Given this list of marker genes TSR1, FIRRM, IARS1, NUP98, PRPS1, MNS1, RFC3, PUS1, EIF2B3, NME1 (NME/NM23 nucleoside diphosphate kinase 1), CDK1, MCM6, RGS4 (NCBI Gene Id 5999), RBM28 (NCBI Gene Id 55131), ELK1, CDC6, MAZ, PARPBP, RRM2 (ribonucleotide reductase regulatory subunit M2), DLEU2, ID1, SNRPD3, TOE1, MCFD2, SEH1L (SEH1 like nucleoporin), COA7, FASN, EBNA1BP2, PKMYT1, RAD51AP1, ODC1, PARP2, TSEN2, CHAF1A, POLR2L, SAR1B, MCM2, POLR1G (RNA polymerase I subunit G), UTP20, TELO2, DNAJC9, SEC23IP, WDR4, PPIF, GINS2, HEATR3, RB1, H2AX (NCBI Gene Id 3014), DHCR24, MTERF3, MLLT10, FXN, IPO4, MPHOSPH9, HNRNPU, RPP40, GNPDA1, TOP3A, FERMT1, PRMT5, LMNB2, DKC1, FUS, TUBG1, CCNE2, VRK1, PUM3, ATP13A3, CUTC, NUP160, RUVBL1, NCS1, VWA8, CENPS, UTP14A, EXOSC8, TIPIN, IDE, SHCBP1, RRP9, MRPL40, HMGA1, VARS1, DHFR, SNRPA1, MRPS12, MAD2L1, MCM10, SLC25A15, MCM3, KIF23, RSAD1 (NCBI Gene Id 55316), ERCC6L, PAIP1, POLE2, SRSF2, TFAM, TTLL4, TPX2, URB2, SKP2, GLRX2, RPP30, BOP1, FBXO5, UBIAD1, PCYT2, NOP16, GEMIN2, ZNG1A, PBK, NLE1, PDSS1, GART, HNRNPDL, NASP, SCLY, POLD2, DDX18 (NCBI Gene Id 8886), RRP1B, ENPP1, BYSL, C3orf52, DBF4, DHCR7, GEMIN6, AASDHPPT, STIL, GCSH, EIF2S1 (eukaryotic translation initiation factor 2 subunit alpha), GINS1, CPN2, GPD1L, ADISSP, METTL2B, ABCF2, PPAT, NOL11, RANBP1, NUP85, FAM136A, HEATR1, CISD1, COQ2, UMPS, POP7, ORC6, TUBB4B, RXYLT1, EXO1, FANCG, NVL, NAT10, SLC25A10, BUD23, NUP205, FANCI, AKAP1, SH2D1A, HACD3, UCHL5, PRC1, MRTO4, SLC5A6, NEK4, PDCD2, NCAPD3, NOLC1, BRCA1, PSMC3IP, FEN1, ATIC, CTPS1, RRM1, EEF1E1, PWP2, PSMG1, WDR12, POLR3G, DDX23, USP39, ZWILCH, SLCO4A1, PAK1IP1, WDR77, MTNAP1, MTHFD1, HNRNPD (heterogeneous nuclear ribonucleoprotein D), PNO1, NUP43, OIP5, ASF1B, LRP8, SNAPC5, ARMC6, CLPB, MFN2, NUP188, ACAT2, H3C4, TSFM (Ts translation elongation factor, mitochondrial), POLR3K, LETM1, RRS1, DDX21, PCLAF, SNRPD1, HMBS, IDH3A, POMT2, ZWINT, NIF3L1, PA2G4, EXOSC2, GRWD1, GTPBP4, NOL12, PHB1, SLC11A2, MRPL46, NUSAP1 (NCBI Gene Id 82534), RFC2, RPL39L, NDUFAF4, MCM5, YARS1, NARS2 (asparaginyl-tRNA synthetase 2, mitochondrial), WDR74, PSME3, PFAS, CCNE1, MAP2K3, RAD51, PRMT7, MELK, DDX19A, TRIP13, AIMP2, DHX35, CAD, GATB, RITA1, GK, PSME4, CENPN, AMDHD2, SRM, CSE1L, LBHD1, GINS3, USP1, POP5, C1QBP, BOLA2, SRRT, PPARD, DNA2, DDX11, PSMD11, MCM4, CCNA2, EMG1, RRP15, SACS, PARP1, RFC5, TRAF3IP3, SLC1A5 (NCBI Gene Id 6510), BARD1 (NCBI Gene Id 580), FBXO42, DGCR11, SLC19A1, TOR3A, CEP83, CDC7, BCS1L, HJURP, ELOVL6, RRP1, URB1, ILF3, GMNN, DLAT, CIAO1, POLA2 (DNA polymerase alpha 2, accessory subunit), CCNF, UBE2S, SPDL1, TUBGCP4, NOP56, NCLN, here is a description of the gene set: species: Homo sapiens Hypoxia-inducible factor 1 (HIF-1) activates transcription of genes encoding angiogenic growth factors, which are secreted by hypoxic cells and stimulate endothelial cells, leading to angiogenesis. To determine whether HIF-1 also mediates cell-autonomous responses to hypoxia, we have compared gene expression profiles in arterial endothelial cells cultured under nonhypoxic versus hypoxic conditions and in nonhypoxic cells infected with adenovirus encoding beta-galactosidase versus a constitutively active form of HIF-1alpha (AdCA5). There were 245 gene probes that showed at least 1.5-fold increase in expression in response to hypoxia and in response to AdCA5; 325 gene probes showed at least 1.5-fold decrease in expression in response to hypoxia and in response to AdCA5. The largest category of genes down-regulated by both hypoxia and AdCA5 encoded proteins involved in cell growth/proliferation. Many genes up-regulated by both hypoxia and AdCA5 encoded cytokines/growth factors, receptors, and other signaling proteins. Transcription factors accounted for the largest group of HIF-1-regulated genes, indicating that HIF-1 controls a network of transcriptional responses to hypoxia in endothelial cells. Infection of endothelial cells with AdCA5 under nonhypoxic conditions was sufficient to induce increased basement membrane invasion and tube formation similar to the responses induced by hypoxia, indicating that HIF-1 mediates cell-autonomous activation of endothelial cells. Human Gene Set: MANALO_HYPOXIA_DN Genes down-regulated in response to both hypoxia and overexpression of an active form of HIF1A. from publication Manalo DJ, Rowan A, Lavoie T, Natarajan L, Kelly BD, Ye SQ, Garcia JG, Semenza GL (PMID 15374877)